Given this list of marker genes MTRR (5-methyltetrahydrofolate-homocysteine methyltransferase reductase), MAT2A, TPMT, HEMK2, GSTO1, CYP1A2, MTR, AS3MT (arsenite methyltransferase), TRMT112, NNMT, MAT1A, COMT, MAT2B, AHCY, here is a description of the gene set: species: Homo sapiens part of: Phase II - Conjugation of compounds Methylation is a common but minor pathway of Phase II conjugation compared to glucuronidation or sulfonation. The cofactor used in methylation conjugation is S-adenosylmethionine (SAM). SAM is the second most widely used enzyme substrate after ATP and is involved in a wide range of important biological processes. SAM is sythesized from methionine's reaction with ATP, catalyzed by methionine adenosyltransferase (MAT). There are two genes, MAT1A and MAT2A, which encode for two homologous MAT catalytic subunits, 1 and 2.<br>During conjugation with nucleophilic substrates, the methyl group attached to the sulfonium ion of SAM is transferred to the substrate forming the conjugate. SAM, having lost the methyl moiety, is converted to S-adenosylhomocysteine (SAH). SAH can be hydrolyzed to form adenosine and homocysteine. Homocysteine can either be converted to glutathione or methylated to form methionine, thus forming the starting point for SAM synthesis and completing the cycle.<br>Fuctional groups attacked are phenols, catechols, aliphatic and aromatic amines and sulfhydryl-containing groups. The enzymes that catalyze the transfer of the methyl group to these functional groups are the methyltransferases (MT). MTs are small, cytosolic, monomeric enzymes that utilize SAM as a methyl donor. There are many MTs but the best studied ones are named on the basis of their prototypical substrates: <i><b>COMT</b> (catechol O-methyltransferase)</i>, <i><b>TPMT</b> (thiopurine methyltransferase)</i>, <i><b>TMT</b> (thiol methyltransferase)</i>, <i><b>HNMT</b> (histamine N-methyltransferase)</i> and <i><b>NNMT</b> (nicotinamide N-methyltransferase)</i>. An example of each enzyme mentioned is given. In each case, a typical substrate for the enzyme is shown. Reactome Pathway: Methylation